The following is a description of a gene set: Any process that increases the rate or frequency of epithelial cell proliferation that results in the lung attaining its shape. Mouse Gene Set: GOBP_POSITIVE_REGULATION_OF_EPITHELIAL_CELL_PROLIFERATION_INVOLVED_IN_LUNG_MORPHOGENESIS studied in species Mus musculus, and this is the list of marker genes: Foxp2, Wnt2, Cdc42, Fgf7, Srsf6, Hmga2, Fgfr2